The following is a description of a gene set: Binding to an intermediate chain of the dynein complex. Human Gene Set: GOMF_DYNEIN_INTERMEDIATE_CHAIN_BINDING species: Homo sapiens, and this is the list of marker genes: MCRS1, BICD1, DNAH2, TRIM58, DNAH10, DNAAF6, DYNC1H1, DYNLT2B, SPTBN5, DNAH14, DNAAF5, DYNLRB2, DNAH1, PAFAH1B1, BAG3, HTT (NCBI Gene Id 3064), DNHD1, DNAH12, DYNLT5, DNAH3, FRRS1L (ferric chelate reductase 1 like), DNAH17, DYNLT3, DYNLRB1, DNAH6, DNAH9, DNAH5, DYNLT4, DNAH11, HOOK3, DYNC2H1, DYNLT1, DYNLT2, RAN, DNAH7, DYNLL1, DNAH8, DYNLL2